Given this list of marker genes Ahr, Cyp11b1, Cyp46a1, Nr1h4, Ncoa2, Fdx1, Cyp7b1, Cyp7a1, Cyp8b1, Pomc, Fdxr, Rxra (retinoid X receptor alpha), Ahrr, Cyp21a1, Cyp11a1, Arnt, Cyp11b2, Cyp51, Fdx2, Cyp27a1, Cyp39a1, Cyp19a1, Cyp4v3, Ncoa1, Cyp1b1, Arnt2, here is a description of the gene set: Mouse Gene Set: REACTOME_ENDOGENOUS_STEROLS Endogenous sterols studied in species Mus musculus